The following is a description of a gene set: Human Gene Set: HP_NEONATAL_HYPERBILIRUBINEMIA species: Homo sapiens Neonatal hyperbilirubinemia A type of hyperbilirubinemia with neonatal onset., and this is the list of marker genes: GYPC (glycophorin C (Gerbich blood group)), EPB41, DUOX2, TPO, IGF1, SLC4A1, DUOXA2, TSHB, TG, SPTA1, KCNN4, SPTB, UGT1A1, IYD, PAFAH1B1, CPOX, PIEZO1, PNPLA6, TSHR, GPX1, UBE2A, FBP1, SLC35A2, SLC5A5